Given this list of marker genes Atp8a1, Tmem30a, Atp11c, Tmem30b, Atp11a, Atp8b1, Atp8a2, here is a description of the gene set: species: Mus musculus Mouse Gene Set: GOMF_AMINOPHOSPHOLIPID_FLIPPASE_ACTIVITY Enables the transfer of aminophospholipids from the exoplasmic to the cytosolic leaflet of a membrane, using energy from the hydrolysis of ATP. Aminophospholipids contain phosphoric acid as a mono- or diester and an amino (NH2) group.